The following is a description of a gene set: studied in species Mus musculus The directed movement of iron (Fe) ions into, out of or within a cell, or between cells, by means of some agent such as a transporter or pore. Mouse Gene Set: GOBP_IRON_ION_TRANSPORT, and this is the list of marker genes: Hsd3b2, Abcc5, Steap4, B2m, Fxn, Scara5, Nos1, Lmtk2, Ftmt, Slc22a17, Slc11a1, Cltc, Slc46a1, Slc48a1, Myo1b, Trf, Meltf, Slc39a14, Heph, Slc25a37, Hsd3b6, Hif1a, Lcn2, Sfxn1, Hamp, Mmgt1, Slc40a1, Mcoln1, Slco2b1, Mcoln2, Ftl1, Pgrmc2, Rab11b, Slc41a2, Hsd3b3, Timd2, Steap3, Fth1, Steap1, Flvcr2, Abcb6, Ifng, Rep15, Arhgap1 (NCBI Gene Id 96949), Ltf, Slc25a28, Inhca, Tfrc, Slc39a8, Slc11a2, Asic3, Dnm2, Hpx, Hamp2, Snx3, Iscu, Abcb7, Flvcr1, Atp7a, Hfe, Fthl17e, Nectin1, Tfr2, Steap2